Given this list of marker genes Chp1, Cfl2, Gabbr2, Prkcg, 4930432M17Rik, Pou4f1, Prrg3, Slfn8, Dnajc3, Dnajc7, Copg2, Prkd2, Kcnma1, Nin, Slc30a10, Boc, Arhgef10, Tmt1a3 (thiol methyltransferase 1A3), Gcnt4, Sh2d1b1, Ctbp1 (NCBI Gene Id 51972), Atp1b4, Ip6k1, Zfp516, Tmtc2, Fndc9, Appbp2, Dmbt1, Scrn3, Cp, Lmcd1, Inava (NCBI Gene Id 74329), Rbbp9, Raver2, Necap1, Cpeb1, Aak1, Dnajc30, Timp3, Jak3, Wdr72, Trio, Camk1d, Sirt2, Cyp2c67, Cyp2c69, Nlgn1 (NCBI Gene Id 99949), Magi1, Abraxas2, Utp18, Map1a, Srrm2 (NCBI Gene Id 75956), Mtx3, Bak1, Plcb2, Mllt11, Ccdc71l, Cftr, Ptp4a2, Sh3rf2 (NCBI Gene Id 269016), Grem2, Daam2, Ebp, Jph3, Mab21l2, Hs3st3b1, Cyp2c40, Cbln3, Mapk8ip3, Arrb1 (NCBI Gene Id 74110), Spata31d1c, Bahd1, Mob3b, Slamf7, Ube2f, Uts2r (NCBI Gene Id 217369), Cnot6, Onecut2, Optc, Cxcr5, Dock5, Ppp1r13l, Gab2, Inka2, Zfp592, Fbxo41, Abcc2, Trem1, Cast, Hspg2, B3gnt7, Itpa, Sh3rf3, Dgkb, Gpatch8, Traf6, Caskin1, Tmt1a2, Mef2d, Tox, Sulf2, Rbms3, Hs2st1, Eda, Trim27, Pabpc4, Ndor1, Aldh1a7, Ggt7, Foxk2, Prdm6, Kpnb1, Cops8, Prokr1, Cdc37l1, Smad9, Ino80d, Xxylt1, Sh3bgr, Tomm40l, Zfp872, Cacna2d1 (calcium channel, voltage-dependent, alpha2/delta subunit 1), Dvl2, Ndufs4, Cdk19, Hif3a, Rtbdn, Entpd8, Clca3a2, Foxn2 (forkhead box N2), Neurog2, Cyb5r2, Meox1, Idh1, Aff4, Vps26c, Kbtbd8, Pipox, Fgf9, Fam120c, Comt (catechol-O-methyltransferase), Galnt6, Cngb3, Igsf23, Dnmt3a, Kcng2, Grm5, Dip2b, Nfasc, Gm266, Gdap1l1, Glt28d2, Spock1, Pet100, Pts, Lyn, Gcn1, Tmem170, Adam30, Acsf2, Lgalsl, Cdh3, Cramp1, Commd6, Tcte2, Vstm4, Faxc, Vangl2, Shisa7, Prkdc, Synpo2l, Eddm3b, Polr1d, Cwf19l1, Sirpa, Rfwd3, Kctd21, Icosl, here is a description of the gene set: Genes predicted to be targets of miRBase v22 microRNA mmu_miR_6907_5p in miRDB v6.0 with MirTarget v4 prediction scores > 80 (high confidence targets). species: Mus musculus from publication Chen Y, Wang X (PMID 31504780) Mouse Gene Set: MIR_6907_5P